Given this list of marker genes TRIB2, NEFM, MOXD1, DUSP4, RGS2, OLFML3, TRIL, TCF4, CCL2, MYL11, SPRY4, GAS2, IGFBP3, TNNC2, NAP1L1, MSTN, PKIA, ZFP36L2, PLK2, ATP2A1, here is a description of the gene set: from publication Davicioni E, Finckenstein FG, Shahbazian V, Buckley JD, Triche TJ, Anderson MJ (PMID 16849537) 'PAX-FKHR signature': genes down-regulated by PAX3- or PAX7-FOXO1 fusion in primary alveolar rhabdomyosarcoma(ARMS) tumors. Human Gene Set: DAVICIONI_PAX_FOXO1_SIGNATURE_IN_ARMS_DN species: Homo sapiens Alveolar rhabdomyosarcomas (ARMS) are aggressive soft-tissue sarcomas affecting children and young adults. Most ARMS tumors express the PAX3-FKHR or PAX7-FKHR (PAX-FKHR) fusion genes resulting from the t(2;13) or t(1;13) chromosomal translocations, respectively. However, up to 25% of ARMS tumors are fusion negative, making it unclear whether ARMS represent a single disease or multiple clinical and biological entities with a common phenotype. To test to what extent PAX-FKHR determine class and behavior of ARMS, we used oligonucleotide microarray expression profiling on 139 primary rhabdomyosarcoma tumors and an in vitro model. We found that ARMS tumors expressing either PAX-FKHR gene share a common expression profile distinct from fusion-negative ARMS and from the other rhabdomyosarcoma variants. We also observed that PAX-FKHR expression above a minimum level is necessary for the detection of this expression profile. Using an ectopic PAX3-FKHR and PAX7-FKHR expression model, we identified an expression signature regulated by PAX-FKHR that is specific to PAX-FKHR-positive ARMS tumors. Data mining for functional annotations of signature genes suggested a role for PAX-FKHR in regulating ARMS proliferation and differentiation. Cox regression modeling identified a subset of genes within the PAX-FKHR expression signature that segregated ARMS patients into three risk groups with 5-year overall survival estimates of 7%, 48%, and 93%. These prognostic classes were independent of conventional clinical risk factors. Our results show that PAX-FKHR dictate a specific expression signature that helps define the molecular phenotype of PAX-FKHR-positive ARMS tumors and, because it is linked with disease outcome in ARMS patients, determine tumor behavior.